Given this list of marker genes PEX16 (peroxisomal biogenesis factor 16), HACL1, PEX1, PEX19, PEX12, ZFAND6, PEX7, LONP2, PEX5, PEX6, here is a description of the gene set: The process of directing proteins towards the peroxisome, usually using signals contained within the protein. Human Gene Set: GOBP_PROTEIN_TARGETING_TO_PEROXISOME studied in species Homo sapiens